The following is a description of a gene set: Cytokines mediate cell-cell communication in the immune system and represent important therapeutic targets. A myriad of studies have highlighted their central role in immune function, yet we lack a global view of the cellular responses of each immune cell type to each cytokine. To address this gap, the authors created the Immune Dictionary, a compendium of single-cell transcriptomic profiles of more than 17 immune cell types in response to each of 86 cytokines (>1,400 cytokine-cell type combinations) in mouse lymph nodes in vivo. A cytokine-centric view of the dictionary revealed that most cytokines induce highly cell-type-specific responses. For example, the inflammatory cytokine interleukin-1β induces distinct gene programmes in almost every cell type. A cell-type-centric view of the dictionary identified more than 66 cytokine-driven cellular polarization states across immune cell types, including previously uncharacterized states such as an interleukin-18-induced polyfunctional natural killer cell state. Mouse Gene Set: CUI_MACROPHAGE_LIF_RESPONSE_UP studied in species Mus musculus Genes positively differentially expressed in cell type: Macrophage upon treatment with cytokine: LIF in mouse lymph nodes in vivo. from publication Cui A, Huang T, Li S, Ma A, Pérez JL, Sander C, Keskin DB, Wu CJ, Fraenkel E, Hacohen N (PMID 38057668), and this is the list of marker genes: Hspa9, Agfg1, Ccl9, Nabp1, Clic4 (chloride intracellular channel 4), Ccl12, Ifi204, Casp4 (NCBI Gene Id 12363), Fcgr3, Mt1, Pnp, Fcgr4, Srsf5, Evl, Nxn, Gatm, Ifitm3, Msrb1, Lgmn, Cd209e, Csde1, Ifitm2, Elac2, Plek, Ccl6, Slfn8, Pirb, Pip4p1, Ccl2, Cxcl9, Ipmk, Akap13, Bin2, Hip1, Mafg, Ifi207, Socs3, Kcnk13, Atp6v1b2, Entr1, Twf1, Rab3il1, Il4ra, Kdm1a, Fcgr2b, Steap4, Cebpb, Fyn, Lrp1, Gab2, Adgrg1, Pla2g15, Srgap2, Junb, Riok3, Ptpn1, Litaf, Gna13, Hfe, Dnm2, Mrfap1, Gbp7, Rbms1 (NCBI Gene Id 98885), Slc16a6, Spic, Wtap, Scimp, Map1lc3b, Mark2, Marchf1, Runx1, Ifi47, Mrap, Spred1, Ddx21, Myd88, Hsbp1, Clec4n, Ms4a6d, Pdgfc, C5ar1, Cebpd, Pim1, Dab2, Rars1, Pik3cd, Stat3, Gbp2, Dok2, Wfdc17, Enah, Yipf6, Osgin1, Snx1, Mafb, Susd6, Dnajc21, B4galt3, Fgr, Ccl7, Zbp1